Given this list of marker genes SLCO3A1, GLYAT, MOXD1, NKX3-1, ELFN2, RFTN1, DIO3OS, BEND4, MISFA, SMC1B, IL2, DNAJC22, IGF1R, HOATZ, DNAH11, KCNN4, GBP6, KIF9, DLGAP1, APOC2, RPRML, HIRIP3, CEBPB, SULT4A1, INPP5B, HSD11B2, KIT, PAWR, TSSK2, MDFI, ANGPT2, MYH7 (myosin heavy chain 7), ETNK1, LY6G6D, MUC16, CNGA2, MFSD2A (NCBI Gene Id 84879, MFSD2 lysolipid transporter A, lysophospholipid), TTC9B, STS, ECE1, TACC2, PLCE1, SLC38A1, ZSWIM2, INCA1, MINAR2, PAK5, TNF (NCBI Gene Id 7124), ZAN, ASPG, KHDRBS2, FGR, TNFSF14, IMPDH2, IL17RC, FHL5, GSX2, GPR15 (NCBI Gene Id 2838), IL7R, DPH1, FCHSD2, KRTAP4-6, PRDX6, RPS15A (ribosomal protein S15a), PARP12, ATP6V1E2, PPP1R1B (protein phosphatase 1 regulatory inhibitor subunit 1B), CFD, HOOK1 (NCBI Gene Id 51361), EGLN3, CCDC18, CHCHD10, ADIG, APCDD1, CXCR3, SLC24A3, INSM2, RIPK3, BTC, SLC25A4, CBX2, C15orf62, DROSHA, ACE, EGR4, TUBA8, KRTAP3-1, RAB3A, NOC3L, EIF2AK2, ZSWIM4, HERC6, SHOX2, LGALS3, NME8, TCAF1, RERE, PLXNA3, IGHM, CPVL, PLA2G2C, GAREM1, SREBF2, ZC3H12D, OPALIN, TMEM18, PPP2R3A, CRACDL, CENPU, PKD2, IKZF4, NIM1K, RAMP1, TLR3, TM4SF20, DAB1, FGFR2, B3GLCT, GP2, SELE, BICDL1, MELTF, AIM2, PENK, CIMIP2A, CXCL2, ICAM4, FAM227A, PRR23A, CD160, TMEM86B, SLC43A3, MAOB (monoamine oxidase B), ARMH3, ARVCF, MCF2L, ABCB4, TMEM200C, DDX25, RNLS, GAL3ST2, KCNK13, PLEKHH1, FAM47E, PDCD1LG2, SERPINA6, CCT8L2, PPIL6, GSC, IP6K3, IGSF23, SPMAP1, TOM1L1, NMUR1, MEGF6, CHCHD6, KDM4D, GYS2, NOL4, NFKB1, CD274, LPXN, BEND5, VWC2 (von Willebrand factor C domain containing 2), TENM2, STAT4, OCIAD2, PLXNC1 (plexin C1), NAP1L2, MGAT4B, PACSIN1, HLA-DOA, PPP1R3G, SARAF, KLF10, SLAMF6, STEAP1, SPAG4, RETREG1, LDHB, RADIL, SPINT2, C3orf85, SH3KBP1, SLC10A1, ZNF572, SNX7, THUMPD2, PGPEP1L, BRD10, CELF2 (NCBI Gene Id 10659), CCSER1, BHLHE22, SLC22A13, DKKL1, RP1, LMOD3, RCSD1, ATP1A3, RPL18, here is a description of the gene set: studied in species Homo sapiens Human Gene Set: GSE13229_MATURE_VS_INTMATURE_NKCELL_UP Genes up-regulated in comparison of mature NK cells versus intermediate mature KN cells. from publication Chiossone L, Chaix J, Fuseri N, Roth C, Vivier E, Walzer T (PMID 19234143) Previous reports have defined three subsets of mouse NK cells on the basis of the expression of CD27 and CD11b. The developmental relationship between these subsets was unclear. To address this issue, we evaluated the overall proximity between mouse NK cell subsets defined by CD27 and CD11b expression using pangenomic gene expression profiling. The results suggest that CD27+CD11b-, CD27+CD11b+ and CD27-CD11b+ correspond to three different intermediates stages of NK cell development.